The following is a description of a gene set: Ebstein-Barr virus LMP1 signaling studied in species Homo sapiens Human Gene Set: WP_EBSTEINBARR_VIRUS_LMP1_SIGNALING, and this is the list of marker genes: IRAK1, HSP90AA1, IFNB1, MAP3K3, MAP3K7, CCL5, TRADD, MAPK8, TRAF6, MAPK1, NFKB2 (nuclear factor kappa B subunit 2), PDLIM7, CCL20, TNF, CHUK, NFKB1, NFKBIA, TRAF1, IKBKG, CXCL8, IKBKB, MAP3K14, RELA